Given this list of marker genes Mmaa, Mmachc, Mtr, Mmab, Mmadhc, Mtrr, Mmut, here is a description of the gene set: Mouse Gene Set: REACTOME_COBALAMIN_CBL_METABOLISM Cobalamin (Cbl) metabolism studied in species Mus musculus